Given this list of marker genes STOX2, P3H2, RAET1E, ZNF468 (NCBI Gene Id 90333), CHM, SASH1, ARHGEF6, COX16, GARIN5A, PPP1CA, TSHZ1, ADAMTS5, FAM220A, ZNF879, FGFR1, PLOD1, EIF3C, ZNF652, TBC1D23 (TBC1 domain family member 23), CHD7, HNF1B (HNF1 homeobox B), MBTD1, EMB, SLITRK4, ADAM22, GOLT1B, ZNF500, NDFIP2, FOXN1, ADRA1B, ARL14EP, EIF3CL, FBRS, DLG5, ZNF346, DNAAF10, PDSS2, TMEM150A, CLDN11 (NCBI Gene Id 5010), NOL7, CCDC83, KIAA1586, PTCHD1, BHLHE22, AGTR2, CCDC180, DNAJB5, ALX1, CSF1, KMT2A, SYNJ2BP-COX16, RSAD2, RHBDD1, HEYL, CFI, PAN3, BSPRY, BMPR2, EXTL2, COL3A1, HHIP, NXPH1, AGL (amylo-alpha-1, 6-glucosidase, 4-alpha-glucanotransferase), RACGAP1, KLF12, RCOR1, UBXN2B, POLR3E, DYNLT5, PODXL, FSD1, HSD11B1, AASDHPPT, FAM83B, RLIM, NPHP1, BNC2, GSDME, GPATCH2L, IQGAP1, IRS1, YBX1, CRIP3, CDC42EP1, MYO5B, TFF3, ACTR2 (actin related protein 2), H2AZ1, ZIC5, WIPF2, DENND1B, ATF1, HTR7, RNF169, NOG, ZNF124, DTX4, BCL11A, CAB39L, ELOA, ATP11C, GOLPH3, RET, RNASE7, ARRB1, LYRM7, RADX, PLA2G6, NEFM, PABPC4, here is a description of the gene set: Human Gene Set: MIR6759_3P Genes predicted to be targets of miRBase v22 microRNA hsa-miR-6759-3p in miRDB v6.0 with MirTarget v4 prediction scores > 80 (high confidence targets). from publication Chen Y, Wang X (PMID 31504780) studied in species Homo sapiens